Given this list of marker genes Atg14, Gabarapl2, Atg7, Ambra1, Atg13, Atg101, Atg12, Atg3, Pik3c3, Atg10, Dctn1, Atg5, here is a description of the gene set: species: Mus musculus Key proteins in mammalian autophagosome formation. Autophagy has been implicated in many physiological and pathological processes. Accordingly, there is a growing scientific need to accurately identify, quantify, and manipulate the process of autophagy. However, as autophagy involves dynamic and complicated processes, it is often analyzed incorrectly. In this Primer, we discuss methods to monitor autophagy and to modulate autophagic activity, with a primary focus on mammalian macroautophagy. Mouse Gene Set: MIZUSHIMA_AUTOPHAGOSOME_FORMATION from publication Mizushima N, Yoshimori T, Levine B (PMID 20144757)